The following is a description of a gene set: species: Mus musculus The directed movement of aminophospholipids into, out of or within a cell, or between cells, by means of some agent such as a transporter or pore. Aminophospholipids contain phosphoric acid as a mono- or diester and an amino (NH2) group. Mouse Gene Set: GOBP_AMINOPHOSPHOLIPID_TRANSPORT, and this is the list of marker genes: Tmem30b, Tmem30a, Atp8a1, Atp8a2, Scarb2, Atp11a, Atp8b1